Given this list of marker genes NRG3 (NCBI Gene Id 219505), HACD3, MTFR2, NDUFAF2, MRPL3, TRIML1, RO60, IMPG2, NUDT6, FEM1C, NENF, UBP1 (NCBI Gene Id 7342), PLD6, DIRAS2, OXLD1, LINC02538, TMEM80, RPL17, FCGR3A, USP16, MOB2, SLC30A3, NAE1, GRPEL2, ZNF491, RPL10A (ribosomal protein L10a), VSX2, ZNF484, PATE1, RSBN1, SULT2B1, DENND4C, RPS3A, HOXD3 (NCBI Gene Id 3232), PAICS, RALA (RAS like proto-oncogene A), COX6C, MOSPD3, DPP7, RGS12, CNGA3, SECISBP2L (NCBI Gene Id 9728), RPL24, AHNAK2, SERBP1, ZBTB33, ADM2 (NCBI Gene Id 79924), CSE1L, ATXN1L, NOSIP (nitric oxide synthase interacting protein), RPL35A, USP24, ATXN10, TMEM67, KSR2, C1orf54, ZFAND2A, SNHG6, DOCK10, ELOVL4, WDR36, RPLP0, ZSWIM7, FAM86B2, STMN3, SRSF7, CAMKMT (calmodulin-lysine N-methyltransferase), SRP72, CFAP74, C11orf96, PCSK1N, KRTAP10-11, POLR2H, TOP3B, NAP1L1 (NCBI Gene Id 64165), CPM, CEBPZ, COMMD3, ZFC3H1, ICOS, USP37, RND2, SNORA49, PRRT1, WDR75, DGCR6, UBE2G2, ARHGEF6 (NCBI Gene Id 9459), FOXD4, BCL11B, IFT46, CCDC59, UBE2Q2, KLHL5, ATP6AP1L, RPS3, FKBP10, LSM7, AK3, LINC02346, CEP41, DLX4, MAT2A, C5orf47, KCTD3, DNAJC15, GOLGA8B, ITK, MICOS13 (NCBI Gene Id 125988), CLDND1, CRB3, H1-1, TRAT1 (NCBI Gene Id 51488), ZZZ3, HS6ST3, DMAC1, CENPX, HNRNPU, HSPE1, RPP40, LYRM7, DHCR7, SUZ12 (NCBI Gene Id 23512), ZNF26, RASGRP1, CNKSR1, TRIB2, XPO4, NUP155, UMODL1-AS1, ATP5PD, TMEM256, SLC7A6 (NCBI Gene Id 9057), PBX4, PLPP6, SLC13A3, NOTO, LINC01931, UXT, SPDYE3, ZNF566, ZFP91, CT55, IL17C, DPH5, RPL3 (ribosomal protein L3), ZNF512B, TRIM73, TMEM126B, COIL, FIBCD1, UBE2E1, IL11RA, NAPEPLD, RPL6, SCNN1B, C19orf53, DYNC1LI2, LINC01554, SLC16A2, GNAT1, ZNF816, RPL18A, CD28, MTERF3, RPL38, EEF1B2, SCN11A, LEPROTL1, RBM15, NAIP, C12orf57, CYP4X1, PTGR2 (prostaglandin reductase 2), PPIL3, SNHG29, CDC40, OR51M1, CAPS (calcyphosine), PRKAA1 (NCBI Gene Id 5562), GPR183, IPO11, TMEM145, MIS12 (NCBI Gene Id 79003), ADO, SMIM11, SNHG32, CUL2, TDG, HSPG2, SOX8, GTF3A, TMEM41B, SRSF6, KRTAP5-1, EIF2S1, LSM3, IQCM, MMGT1, DENND1B (NCBI Gene Id 54530), CSNK1A1, STYX, TRIM4, NSG2, RD3, H1-3, SC5D, ARMC8, HMGCS1, EIF3E, PER2, SLC30A7, RPS6, EIF3H, ZMYND11, CAMLG (calcium modulating ligand), ITM2A, RBM12, PLEKHA1, TARDBP, OR2W5P, INTS6 (NCBI Gene Id 26512), HCAR3, FBXO5, CLTCL1, NNAT, here is a description of the gene set: species: Homo sapiens Human Gene Set: KANNAN_BLOOD_2012_2013_TIV_AGE_65PLS_REVACCINATED_IN_6_9_MO_VS_REVACCINATED_IN_12_13_MO_UP from publication Kannan S, Kossenkov A, Kurupati RK, Xiang JZ, Doyle SA, Schmader KE, Schowe L, Ertl HC (PMID 26637961) We tested antibody responses to the trivalent inactivated influenza vaccine (TIV) in 34 aged individuals ( > 65 yrs) during the 2012/13 vaccination seasons. Nearly all had been vaccinated the previous year although the time interval between the two vaccine doses differed. One subgroup was re-vaccinated in 2012/13 within 6-9 months of their 2011/12 vaccination, the other received the two doses of vaccine in the typical ~12 month interval. Unexpectedly the sub-cohort with early revaccination exhibited significantly increased response rates and antibody titers to TIV compared to their normally re-vaccinated aged counter parts. Microarray analyses of gene expression in whole blood RNA taken at the day of the 2012/13 re-vaccination revealed statistically significant differences in expression of genes between the individuals with early re-vaccination compared to subjects vaccinated in a normal 12 month interval. These observations suggest that TIV has long-lasting effects on the immune system affecting B cell responses as well as the transcriptome of peripheral blood mononuclear cells and this residual effect may augment vaccination response in patients where the effect of the previous vaccination has not yet diminished. Genes up-regulated in blood cohort 1 (re-vaccinated in 6-9 months) vs cohort 2 (re-vaccinated in 12-13 months) in adults (65+) after exposure to 2012-2013 seasonal trivalent inactivated influenza vaccine (TIV), time point N/A. Comment: Cohort 1 (re-vaccinated in 6-9 months) vs Cohort 2 (re-vaccinated in 12-13 months)